Given this list of marker genes Psma3, Ube2d1, Anapc4, Psmb5, Psmb6, Anapc2, Psmc2, Anapc1, Anapc5, Psmc1, Rps27a, Psmc5 (NCBI Gene Id 19184), Pttg1, Psmc3, Psma4, Psmd13, Aurka, Ube2c, Anapc7, Psmd3, Psma6, Cdc27, Psmd8, Psmd6, Psmd1, Ubb, Psmb2, Skp2, Psma5, Psmd14, Uba52, Psmd12, Psmb1, Cdc20, Anapc16, Anapc10, Cdc26, Fzr1, Psmb3, Psmd11, Plk1, Psma1, Psmd7, Ube2s (ubiquitin-conjugating enzyme E2S), Anapc15, Ube2e1, Rb1 (NCBI Gene Id 19645), Psma7, Anapc11, Adrm1, Cdc16, Cdc23, Psmb7, Psmd2, Psma2, Ubc, Psmb4, Psmc4, Aurkb, Uba52rt, Psmc6, here is a description of the gene set: studied in species Mus musculus Mouse Gene Set: REACTOME_APC_C_CDH1_MEDIATED_DEGRADATION_OF_CDC20_AND_OTHER_APC_C_CDH1_TARGETED_PROTEINS_IN_LATE_MITOSIS_EARLY_G1 APC/C:Cdh1 mediated degradation of Cdc20 and other APC/C:Cdh1 targeted proteins in late mitosis/early G1